Given this list of marker genes RPGRIP1L, NAA10, FREM1, RPGRIP1, RBP4, BMP4, POMT2, SF3B2, FKRP, SMCHD1, SIX6 (SIX homeobox 6), TMEM107, COX7B, LARGE1, GRIP1, HCCS, GLI2, POMT1, RXYLT1, TMEM237, SEMA3E, TCTN3, KIF7, CHD7, MKS1, RAX, ERCC1, RARB, FKTN, WNT7B, FANCB, SOX2, OTX2, PORCN, HYLS1, B4GAT1, POMGNT2, CC2D2A, ERCC4, STRA6 (signaling receptor and transporter of retinol STRA6), B3GALNT2, CRPPA, FRAS1, TXNDC15, POMK, POMGNT1, CEP290, NDUFB11, TFAP2A, ALDH1A3, COL4A1, BCOR, DOCK7, TMEM216 (NCBI Gene Id 51259), ERCC6, SMOC1, KIF11, MAB21L2, TCTN2, B9D2, SHH, FREM2, TCTN1, NUAK2, CSPP1, TMEM231, TMEM67, DAG1, B9D1, ERCC8, here is a description of the gene set: studied in species Homo sapiens Human Gene Set: HP_ANOPHTHALMIA Anophthalmia Absence of the globe or eyeball.